The following is a description of a gene set: Human Gene Set: DESCARTES_FETAL_HEART_ENDOCARDIAL_CELLS studied in species Homo sapiens from publication Cao J, O'Day DR, Pliner HA, Kingsley PD, Deng M, Daza RM, Zager MA, Aldinger KA, Blecher-Gonen R, Zhang F, Spielmann M, Palis J, Doherty D, Steemers FJ, Glass IA, Trapnell C, Shendure J (PMID 33184181) Marker genes curated from the annotated cluster as represented in the Descartes Human Gene Expression During Development database. The gene expression program underlying the specification of human cell types is of fundamental interest. The study authors generated human cell atlases of gene expression and chromatin accessibility in fetal tissues. For gene expression, the study authors applied three-level combinatorial indexing to >110 samples representing 15 organs, ultimately profiling ~4 million single cells. The study authors leveraged the literature and other atlases to identify and annotate hundreds of cell types and subtypes, both within and across tissues. Our analyses focused on organ-specific specializations of broadly distributed cell types (such as blood, endothelial, and epithelial), sites of fetal erythropoiesis (which notably included the adrenal gland), and integration with mouse developmental atlases (such as conserved specification of blood cells). These data represent a rich resource for the exploration of in vivo human gene expression in diverse tissues and cell types., and this is the list of marker genes: LYPD2, LEPR, SLCO2A1, ANGPTL5, FAM3D, HS3ST1, HAPLN1, LRATD1, ST6GALNAC1, FOXC1, PWWP3B, CDH11, SALL1, SLC6A4, LINC01896 (long intergenic non-protein coding RNA 1896), MPZL2, TMEM100, NPPC, QSOX1, INHBA, LINC01497, CA12, SOST, RASSF10-DT, WNT9B, SALL3, CPXM2, ITGA8, LINC02261, LINC01320, TMEM132C, CGNL1, ENSG00000273132, PDE3A-AS1, SMOC1 (SPARC related modular calcium binding 1), APCDD1, HMCN1, APCDD1L, LINC01099